Given this list of marker genes CTR9, LATS1, PRDM14, HNF1B, NLE1, SOX17, LATS2, TET1, TFAP2C, NR5A2, here is a description of the gene set: species: Homo sapiens Human Gene Set: GOBP_INNER_CELL_MASS_CELL_DIFFERENTIATION The process in which a relatively unspecialized cell acquires specialized features of an inner cell mass cell.